The following is a description of a gene set: Immune cell-specific expression is one indication of the importance of a gene's role in the immune response. In order to identify such patterns, we set out to broadly profile gene expression in a variety of immune cells. Human Gene Set: GSE22886_IGM_MEMORY_BCELL_VS_BM_PLASMA_CELL_UP species: Homo sapiens from publication Abbas AR, Baldwin D, Ma Y, Ouyang W, Gurney A, Martin F, Fong S, van Lookeren Campagne M, Godowski P, Williams PM, Chan AC, Clark HF (PMID 15789058) Genes up-regulated in comparison of memory IgM B cells versus plasma cells from bone marrow and blood., and this is the list of marker genes: POGZ, ZNF573, MRPS35, NFYB, HLA-DMB, WDFY3, NCR3, RASGRP2, ING1, PNRC2, GARRE1, BBS7 (NCBI Gene Id 55212), TDP2 (NCBI Gene Id 51567), ADD3, ESD, NOTCH2NLA, FAM13B, CCT5, ARHGAP24, MORC3, PLCXD1, RPL12, RBL2, ZNF22, INPP5D, SYNRG, ATP6V1B2, PAX5, RPL11, APC, CRYZL1 (NCBI Gene Id 9946), WDR3, FAM111A, STAT6, ZBTB18, C2CD5, CD79B, ABHD17A, HLA-DMA, HMBOX1, CR2, HSP90AB1, CD1C, ANKH, PKIG, VNN2, IRF8, CFL1, SLC25A24, KIF21B, FSTL1 (follistatin like 1), PVRIG, DENND4B, RPSA, PLAGL1, SLC24A1, SENP5, BIN1, TRIM22, RPS7, MANBA, KYNU, RPL23, PRKACB, ENDOD1, CASP8AP2, DNM3, SRSF5, DYNC1LI1, RNF111, PTPRK, JADE2, NASP, LYST, TENM1, DGKD, TSC22D1, PPID, RPL23A, SP110, RPS2, VAPB, ELOVL5, LCOR, PKIA, RPS29, SYPL1, PMS2P5, SGPP1, POLD3, CDKN2D (NCBI Gene Id 1032), PIK3CD, GSAP, CDC40, GGA2 (golgi associated, gamma adaptin ear containing, ARF binding protein 2), MAPRE2, SET, LRRC31 (NCBI Gene Id 79782), NUP43, SNX10, RADX, BAZ1A, CD74, SACS, NOTCH2, PSTPIP2, ZKSCAN7, RIPOR2, MAT2B, NIPSNAP1, RPS28, LY86 (lymphocyte antigen 86), LSP1, ESYT1, CAT, SF3A2, RFX5, STRADA, TRIB2, TTC31, SEPTIN7, ZNF267, SLC4A4, PRRC2B, PTMA, TNFAIP8, DENND5A, RPA2 (replication protein A2), RPS20, BRD3, KLRG1, PTPN18, APP, ARHGDIB, AGL, TIA1, RALYL, REL, EEF1A1 (NCBI Gene Id 96648), OCA2, NSUN5P2, SIPA1, SIDT2, ITSN2, RPL31, TOPBP1, STK24, SORL1, FNBP1L, KIF13A, GCA (grancalcin), PPP1R16B, THAP12, MARCHF1, IKBKB, RPL17, PRKCB, SNN, ARHGAP15, CD72, GABBR1, SUPT16H, DCK, OPHN1, DGKA, S1PR1, CORO1A, SNHG20 (small nucleolar RNA host gene 20), IKZF3, TRMT13, RFC3, UGT2B4, NSL1, TGFBR2, FRY, TRIM38, AKAP11, MINDY2 (MINDY lysine 48 deubiquitinase 2), PPP1R12A (NCBI Gene Id 4659), BACH2, OPA1, CSF1, MTF2, QRSL1, RAP1GDS1, ABCA7, RUBCNL, RPL27, NDC1, RPL39, PSPC1, ARHGAP45, CRYBG1, RBM34, RBM5, USP25, TCFL5, EGLN2, RPL26, KAT6A